The following is a description of a gene set: PURPOSE: To elucidate the molecular mechanisms contributing to the unique clinicopathologic characteristics of mucinous ovarian carcinoma, global gene expression profiling of mucinous ovarian tumors was carried out. EXPERIMENTAL DESIGN: Gene expression profiling was completed for 25 microdissected mucinous tumors using Affymetrix U133 Plus 2.0 oligonucleotide microarrays. Hierarchical clustering and binary tree prediction analysis were used to determine the relationships among mucinous specimens and a series of previously profiled microdissected serous tumors and normal ovarian surface epithelium. PathwayAssist software was used to identify putative signaling pathways involved in the development of mucinous LMP tumors and adenocarcinomas. RESULTS: Comparison of the gene profiles between mucinous tumors and normal ovarian epithelial cells identified 1,599, 2,916, and 1,765 differentially expressed in genes in the cystadenomas, LMP tumors, and adenocarcinomas, respectively. Hierarchical clustering showed that mucinous and serous LMP tumors are distinct. In addition, there was a close association of mucinous LMP tumors and adenocarcinomas with serous adenocarcinomas. Binary tree prediction revealed increased heterogeneity among mucinous tumors compared with their serous counterparts. Furthermore, the cystadenomas coexpressed a subset of genes that were differentially regulated in LMP and adenocarcinoma specimens compared with normal ovarian surface epithelium. PathwayAssist highlighted pathways with expression of genes involved in drug resistance in both LMP and adenocarcinoma samples. In addition, genes involved in cytoskeletal regulation were specifically up-regulated in the mucinous adenocarcinomas. CONCLUSIONS: These data provide a useful basis for understanding the molecular events leading to the development and progression of mucinous ovarian cancer. Human Gene Set: WAMUNYOKOLI_OVARIAN_CANCER_LMP_UP Genes up-regulated in mucinous ovarian carcinoma tumors of low malignant potential (LMP) compared to normal ovarian surface epithelium tissue. studied in species Homo sapiens from publication Wamunyokoli FW, Bonome T, Lee JY, Feltmate CM, Welch WR, Radonovich M, Pise-Masison C, Brady J, Hao K, Berkowitz RS, Mok S, Birrer MJ (PMID 16467078), and this is the list of marker genes: RABL6, GOLGA2, NDUFAF2, OXLD1, GMDS (GDP-mannose 4,6-dehydratase, NCBI Gene Id 2762), GSS, MRPL41, ELL3, C1GALT1, TMEM30B, QSOX1, GALNT7 (NCBI Gene Id 51809), DNTTIP2, OVOL2, ABCC3, ESRP1, CRB3, TPT1, UQCC3, LLGL2, CDC42EP5, PET100, UBE2V1, EPCAM, PLS1 (plastin 1), GIPC1, SGSM3, SURF6, ZMYND8, UBA7, FA2H, ESRP2, C3orf52, PREP, KRTCAP3, EIF4G1, TXN, TMEM63A, NANS, ZGPAT, ZNF564, KDELR2, RNF128 (NCBI Gene Id 79589), CHPT1, ALAS1, TUBA4A, HDAC1, ATP8B1, ABHD6 (NCBI Gene Id 96026), ARRDC2, BAG1, EDF1, PLEKHH1, AGR3, RALY, CCDC107, IMPA2, ABHD17C, VSIG2, CANT1, CAMK2N1 (calcium/calmodulin dependent protein kinase II inhibitor 1), CXXC5, FMO5, CACFD1, TMC6, SFN, HMGB1, MRAP2, LSM7, CIB1, ARSD (NCBI Gene Id 414), TALDO1, RABEP2, EPS8L2, MROH1, TMEM129, RNF126, ELF3, MFSD9, TNFSF10, ACTB, IQGAP2, F11R, RPS6KA1, NET1, SLC2A10, DYRK2, TPM4, UNC5CL, GFPT1, POP7, AURKAIP1, DHTKD1, TM9SF3, MANSC1 (MANSC domain containing 1), TTC22, B3GNT5, BZW2 (NCBI Gene Id 28969), MRPL14, PLAC8, GTPBP6, TRAK1, RALA, ACBD5, SYTL2 (NCBI Gene Id 84564), TNIP2, C19orf33, GNA11, LRRC8B, DNAJA4, CEBPZ, TTLL12, BACE2, TOP1, SIRT7, TRAF4, NADSYN1, SLC22A23, FAAP100, MUC1, CHMP1A, ANKRD9, C9orf152, GPR160, ABCD3, GSTP1 (glutathione S-transferase pi 1), GRTP1, ATP1B1, MCRIP2, MRPL52, INF2, RASEF, DOHH, TMEM125, BPHL, GALNT4, FAM174B, ICA1, MLLT6, TOX3, MLPH, STARD10, FDFT1, ACAA1, IFI27, MVP, GFUS, FOXQ1, SH3BGRL2, CD24, ARHGAP27, PRXL2B, CENPV, FAM83H, BDP1, FRK, EHF, MGLL, SMARCA4, EFHD2, EPHB4, COX6A1, UBALD2, AKAP13, LMAN2, TSPAN8, PABPC1P3, ETFB, TEX264, BTBD3, JTB, TRAPPC5, CHMP4C, UQCRQ, GSTK1, MYO10, MT-ATP6, POLR1H, C4orf19, DOK4, C8orf82, PSD4, ARPC5L, TMC5, AACS, CLPTM1L, TNIP1, MED16, DDAH1, FLNB, LBHD1, HPGD, STYK1, EBP, TJP3, RRBP1, SCAMP2, KLF5, SGPP2, TC2N, AKR1C3, S100A6, NQO1, HIP1R, EIF5B, TOMM40, TACSTD2, PACSIN2, MARVELD2, DNAJB2, C1orf116, SLC35A3 (NCBI Gene Id 23443), CTBP2, MECOM, BSPRY, ARRDC1, PWWP2B, GALE, MPST, CTSE, SRPK1, MKNK2 (MAPK interacting serine/threonine kinase 2), LZIC, NOSIP, HM13, IL20RA, IER3, RPS27L, SERPINB1, CC2D1A, VSIG10, PPDPF, FUT2, RRP7A, VPS37B, PLPP2, ST14, ABHD11, HDLBP, CNPPD1, PLEKHJ1, EIF2B5, RAB25, MRPS18A, FXYD3, RAB2A, ATP5MK, ERBB3, MYO18A, HSP90AA1, POR, PSMB10, UQCR11, CCNDBP1, MYO6 (myosin VI), COX7A2, GALNT3, FNIP2, SLC35D2 (NCBI Gene Id 11046), CD59, TMEM259, DBI, AGR2, PPIA (NCBI Gene Id 5478), NOP58, MYL12B, ACY1, BAIAP2L1, CCND1, SART1